The following is a description of a gene set: species: Homo sapiens Delayed somatosensory central conduction time An abnormal increase (delay) in the somatosensory central conduction time (CCT), which can be measured from the peak of N13 to the peak of N20 (peak CCT) or from the onset of N11 to the onset of N20 (onset CCT). Human Gene Set: HP_DELAYED_SOMATOSENSORY_CENTRAL_CONDUCTION_TIME, and this is the list of marker genes: CYP27A1, ALS2, HYCC1 (NCBI Gene Id 84668), TTPA, ABCD1